The following is a description of a gene set: species: Mus musculus Mouse Gene Set: GOBP_NEUROTRANSMITTER_RECEPTOR_TRANSPORT_TO_PLASMA_MEMBRANE The directed movement of neurotransmitter receptor to the plasma membrane in transport vesicles., and this is the list of marker genes: Snap47, Epb41l1 (erythrocyte membrane protein band 4.1 like 1), Camk2a, Snap23, Nsg1, Clstn1, Sacm1l, Gripap1, Scrib, Grip1, Vamp2, Mylk, Vps35, Snx27, Stx3, Myo5b, Grip2, Slc1a1, Cplx1, Lrrc7, Stx4a, Rab8a, Rab11a (NCBI Gene Id 53869), Mapk10, Stx1b (NCBI Gene Id 79361), Arhgap44